Given this list of marker genes TMX3, ZNF704, THBS1, ZNF112, PIK3R3, THAP2, ARNT2, SLC66A3, KCNB1, ANXA7, PLCB4, PHF12, ZNF322, PPARGC1A, DAAM2, ZCCHC7, PJA2, EEF1AKMT3, LYVE1, TENM1, PRICKLE2, EIF4A2, UNC13C, ZNF813, CELF3, OXCT1, PCDH1, CADPS2, PSAT1, NOVA1, G3BP2, BTRC, SMG7, KCNV1, TRAM1, MYO6, KDELR3, SOX6, P3R3URF-PIK3R3, MBTD1, SLC25A36, CACNA2D1, KCNIP2, SIGLEC12, CTSO, MYCT1, KLHL24 (NCBI Gene Id 79965), CBLN1, CCDC141, KGD4, SESN3, ZNF891, CCSER1, DSC1, HEXA, TIPIN, IL6, NPAT, LRP6, PBX1, ANKRD44, VOPP1, EIF1B, MYSM1 (Myb like, SWIRM and MPN domains 1), PDIA3, ITGBL1, CBX5, ATP2C1, MOB1B, PHLPP2, USH1G, SYNJ1, ZC3H6, NTRK2, LSM12, ZNF132, MMGT1, LAMP2, RHOBTB3, ABCC9, LRR1, UGP2, KBTBD6, TRIM27, MTDH, CDIPT, BCAT1, CTDSPL2, PLEK, CDK5RAP3 (CDK5 regulatory subunit associated protein 3), ZNF641, ZNF670, TRAPPC11, SHC3, XRCC5, PMF1, HCFC2, SAMD4B, MED13L, ATG3, RAB6B, CDYL2, MAGEA1, POU3F2, MMRN1, ENY2, HSPA13, EIF3J, ADARB1, DOCK2, KLHL4, ST7L, DLX1, ABCG2, FRS2, CYP7B1, ZNF275, SCAI, TBC1D24, ZC3H4, YWHAG, CD80, MIS18BP1, SETD7, SKA2, BLZF1, CD276, CACNA2D3, TMPRSS11E, TMEM74, TFCP2L1, KDELR1, CYP27C1, NFE2L1, GDNF, SGCB, ANKRD60, USP25, RAB39B, JRKL, HACD4, STRBP, STK17B, CYB5D1, SFMBT1, ACE2, CDK6, CST9, DCUN1D4, MOB3B, CAMK2D, SMIM43, CARD8, here is a description of the gene set: studied in species Homo sapiens Human Gene Set: MIR3925_5P from publication Chen Y, Wang X (PMID 31504780) Genes predicted to be targets of miRBase v22 microRNA hsa-miR-3925-5p in miRDB v6.0 with MirTarget v4 prediction scores > 80 (high confidence targets).